The following is a description of a gene set: studied in species Mus musculus Mouse Gene Set: REACTOME_KSRP_KHSRP_BINDS_AND_DESTABILIZES_MRNA KSRP (KHSRP) binds and destabilizes mRNA, and this is the list of marker genes: Dis3, Ywhaz, Parn, Akt1, Exosc5, Exosc3, Exosc9, Exosc7, Exosc1, Exosc2, Exosc6, Exosc8, Exosc4, Dcp2 (decapping mRNA 2), Khsrp